The following is a description of a gene set: Reactome Pathway: Defective binding of RB1 mutants to E2F1,(E2F2, E2F3) This pathway describes impaired binding of RB1 pocket domain mutants to activating E2Fs, E2F1, E2F2 and E2F3. species: Homo sapiens part of: Aberrant regulation of mitotic G1/S transition in cancer due to RB1 defects, and this is the list of marker genes: RB1, CCND1, CDK6, CCNE2, CDKN1C, CCND2, CDK4, TFDP1, TFDP2, CDKN1B, CCNE1, E2F2, E2F1, CDK2, E2F3, CDKN1A, CCND3